The following is a description of a gene set: Signaling by VEGF studied in species Mus musculus Mouse Gene Set: REACTOME_SIGNALING_BY_VEGF, and this is the list of marker genes: Prkacb (protein kinase, cAMP dependent, catalytic, beta), Vav1, Mlst8, Pak2, Mapkapk3, Pgf, Crk, Pxn, Nrp1, Kras, Mapk11, Pik3r2, Axl, Them4, Pdpk1, Itgav, Vav2, Abi2, Cybb (cytochrome b-245, beta polypeptide), Calm1, Ptk2b, Dock1, Kdr, Ncf1, Cyfip2, Fyn, Cdc42, Plcg1, Hspb1, Hsp90aa1, Shc2, Pik3r1, Actb, Pik3ca, Itgb3, Jup, Trib3, Vegfa, Flt4, Rictor, Mapkap1, Rhoa, Cyba, Abi1, Vav3, Nckap1, Mapk14, Vegfc, Calm2, Sh2d2a, Pak3, Ncf4, Prr5 (proline rich 5 (renal)), Akt1, Ctnnd1, Pak1, Calm3, Wasf1, Shb (NCBI Gene Id 230126), Prkcd, Mapk13 (NCBI Gene Id 26415), Flt1, Mapkapk2, Brk1, Prkcz, Akt3, Baiap2, Rock1, Hras, Actg1, Nos3, Elmo2, Src, Rock2, Ptk2, Akt2, Bcar1, Nckap1l, Ncf2, Prkcb, Vegfd, Mtor, Rac1, Cyfip1, Elmo1, Rasa1, Sphk1, Cav1 (caveolin 1, caveolae protein), Cdh5, Mapk12, Prkaca, Vegfb, Ctnna1, Nck2, Ctnnb1, Wasf3, Wasf2, Nrp2, Pik3cb, Nck1